The following is a description of a gene set: Genes predicted to be targets of miRBase v22 microRNA mmu_miR_5627_5p in miRDB v6.0 with MirTarget v4 prediction scores > 80 (high confidence targets). studied in species Mus musculus from publication Chen Y, Wang X (PMID 31504780) Mouse Gene Set: MIR_5627_5P, and this is the list of marker genes: Tmprss15, Etv6, Ppp3cb, Pcdh20, Nkd2, Dcaf12, Lrsam1, Unc5b, Chmp7, Myrf, Akr1c20, Cbarp, Gm4841, Tent4b, Mrgprb2, Htt, Pip4k2b, Ntrk1, Epb41l5, Cdk5rap2, Fkbp1a, Sema4g, Rabggta, Erc1, Dpysl5, Ubl4a, Serinc5, Sptbn2, Mtcl2 (microtubule crosslinking factor 2), Pacsin1, Plekha8, Zfp273, Rnf123, Anapc5, E2f4, Hdac9 (NCBI Gene Id 79221), Ugt2b38, Gls, Sorbs2 (NCBI Gene Id 77324), Rab35, Hcfc1, Rprd2, Tmem230, Cnst, Iqsec2, Anxa10, Ophn1, Tgm6, Sgsm1, Stk4, Zfp987, Nos1, Syncrip